The following is a description of a gene set: studied in species Mus musculus Mouse Gene Set: CUI_CDC1_IFNA1_RESPONSE_UP Cytokines mediate cell-cell communication in the immune system and represent important therapeutic targets. A myriad of studies have highlighted their central role in immune function, yet we lack a global view of the cellular responses of each immune cell type to each cytokine. To address this gap, the authors created the Immune Dictionary, a compendium of single-cell transcriptomic profiles of more than 17 immune cell types in response to each of 86 cytokines (>1,400 cytokine-cell type combinations) in mouse lymph nodes in vivo. A cytokine-centric view of the dictionary revealed that most cytokines induce highly cell-type-specific responses. For example, the inflammatory cytokine interleukin-1β induces distinct gene programmes in almost every cell type. A cell-type-centric view of the dictionary identified more than 66 cytokine-driven cellular polarization states across immune cell types, including previously uncharacterized states such as an interleukin-18-induced polyfunctional natural killer cell state. from publication Cui A, Huang T, Li S, Ma A, Pérez JL, Sander C, Keskin DB, Wu CJ, Fraenkel E, Hacohen N (PMID 38057668) Genes positively differentially expressed in cell type: cDC1 (conventional dendritic cell type 1) upon treatment with cytokine: IFN-α1 in mouse lymph nodes in vivo., and this is the list of marker genes: Traf1, Ccnd3, Fcer1g (Fc receptor, IgE, high affinity I, gamma polypeptide), Sec23b, Efhd2, Rcn2, Arpc5l, Nmi, Pbx1, Elac2, Fam241a, Srgn, Tapbpl, Etnk1, Dusp2, Rigi, Icam1, Sgcb, Ifi27l2a (NCBI Gene Id 76933), Xaf1, Tent2, Arf4, Usp15, Irf5, Cnp, Lap3, Mov10, Cd40, Rab7, Irgm1, Sdcbp, Prpf38b, Herc6, Pttg1ip, Tspo, Tpm3, Itga4, Ppa1, Ankrd17, Cdh15, Pgd, Zbp1, Arpc5, Max, Peli1, Selplg, Prkx, Ifi203, Zc3h12c (NCBI Gene Id 330940), Atp6v1g1, Fgl2, Ncoa7, Oasl2, Dtx3l, Apod, Dnaja1 (DnaJ heat shock protein family (Hsp40) member A1), Fbxw17 (NCBI Gene Id 97893), Gpr33, Ass1, Ap1g2, Il10ra, Naa20 (NCBI Gene Id 99228), Mycbp2, Tent5c, Trim34a, Parp12, P2ry14, Ttc39b, Capza2, Ifit3, Dnase1l3, Npc2, Gbp4, Aida, Zfp800, Mbd2, Scimp, Ifi205, Arhgap17, Flnb, Trim25, Vim, Psma4, Phf11a, Sema4f, Parp9, Ccdc86, Cyba, Map2k1, Cd86, Rbms1, G3bp2, Bag1, Tppp3, Acot9, Hk3, Nufip1, Cst3, Fcgr4 (Fc receptor, IgG, low affinity IV), Rnh1, Dnaja2, Dck, Gch1, Sar1a, Psme1, Ikzf1, Myd88, Gng5, Il27, Usp25, Ogfr, Serpinb9, Itgb1, Pmepa1, Eapp, Prdx1, Sri, Gadd45b, Neat1, Calm1, Cfap126, Rngtt, Otud5, Rab5c, H2-T22, Cdkn1a, Sco1, Cybb (cytochrome b-245, beta polypeptide), Tbl1x (transducin (beta)-like 1 X-linked), Ifi47, Lnpep, Cdc42bpg, Selenow, Phyh, Oasl1, Mitd1, Gpr157, Ifit3b, Nfkb2, Ywhae, Ddx24, Bbx, Sat1, Herpud1, Cd52, Serpina3g, Usp18, Hck, Acadl, Hsp90aa1, Keap1, Naa25, Akr1a1, Cd47, Lyn, S100a6, Lamp2, Pnp, Macir, Ifi206, Epsti1, Grb2, Nlrc5, Phf11b, Scarb2, Kpna3, H3f3b, Gng12, Hsd17b11, Cdc42 (NCBI Gene Id 12540), Mthfr, Pttg1, Psmb10, Ly75, Trim12a, Sh3glb1, Ywhah, Glrx, Ifi209, Plxnc1, Tbc1d1, Ifi35, Mpc1, Ildr1, Relb, Sfxn1, Rap2a (NCBI Gene Id 76108), Itm2b, Tapbp, Pgap2, Casp3, Bcl2a1b, Cd8a, Fchsd2, Hmgn3, Tmem184b, Pml, Tor1aip2, Iigp1, Srsf5, Reep3, Mtmr14, Arhgap8, Anxa7, Phf11c, Ehd1, Csrp1, Macroh2a1, Cln3, Map3k8, Sell, Mfsd12, Tpm4, Etv3, Ly6a, Stx11, Psme2, Grn, Ifi207, Slfn8, Themis2, Lgals3, Gatm, Samhd1, Ints8, Apool, Dusp5, Gbp9, Trim12c, Rtp4, Cxcl10, Nuak2, Vcpip1, Ifi208, Ifi204, Ttc7, Fbxo6, Tomm70a (translocase of outer mitochondrial membrane 70A), Vrk1, Cmtm6 (CKLF-like MARVEL transmembrane domain containing 6), Gng2, Tor1aip1, Trafd1, Tmpo, Nr4a3, H2-T23, M6pr, Cflar, Nsd3, Armcx3, Pmpcb, Psma3, Stat1, Snap23, Parp14, Hnrnph2, Il15, Oas1a, Stat2, Ppp1r2, Mcmbp (minichromosome maintenance complex binding protein), Sp100, Tle3, Trim30b, Slc25a22, Dnajc13, Isg20, Ehd4 (EH-domain containing 4), Mxd1, Timeless, Fbxw11, Morc3, Trim30d, Ndrg1, Aldh1b1, Stoml1, Igtp, Plaat3, Rnf114, Bri3, Tnfrsf1a (tumor necrosis factor receptor superfamily, member 1a), Ifih1, Tgtp1, Cpne2, St8sia1, Pik3cd, Slfn1, Gbp2, Pdha1, Slfn2, Rab11a, Cpne3, H2-K1, Phc2, Brd2, Hspa5, Rnf19b, Smg7, Map3k12, Rnf4, Ccnd1, Tomm34, Snx6, Map3k14, Spi1, Myl12a, Rnf213 (ring finger protein 213), Tcstv4, Slc8b1, Psma2, Anxa2, Nsmce1, Phf11d, Anxa1, Rrad, Triobp, Asb2, Xdh, Uqcrb, Lgals3bp, Card11, Atp1b3 (ATPase, Na+/K+ transporting, beta 3 polypeptide), Dek, Zc3hav1 (zinc finger CCCH type, antiviral 1), Nudt9, Stard3, Sap30, Cd38, Sppl2a, Ube2d3, Rufy3 (NCBI Gene Id 72186), Chmp4b, H2-D1, Bst2, Larp1b, Atp6v1e1, Rasa4, Ctsz, Mcl1, Tmem106a, Dbnl, Serpina3f, Laptm4b, Cd69, Anxa5, Lpxn, Csprs, Pfkp, Apobec3, Tdrd7, Procr, Rtraf (RNA transcription, translation and transport factor), Sdc3, Irf7, Ubr4, Inpp5b, Actr2, B4galt5, Oas3, Rnf34, Crlf3, Stxbp3, Gramd2b, Cct3 (chaperonin containing TCP1 subunit 3), Dhx58, Pcgf5, Adar, Ostf1, Uba7, Samd9l, Rsad2, Zyx, Nono, Trim30a, Ms4a6c, Gca, Tmem219, Daxx, Lpp, Ppp1r11, Plin2, Nfkbie, Pdia3 (NCBI Gene Id 18794), Treml2, Trib1, Ascc3, Bcl9, Tor3a, Krcc1, Bcl2a1d, Cmpk2, Sp140, Gypc, Nipsnap3b, Slfn5, Ms4a4b, Utp3, Sumo1, Cacybp, Eif2ak2, Kynu, Gnb2, Rab8a, Clec2d, Gnb4, Ciao2b, Helz2 (NCBI Gene Id 229003), Ly6c2, 9930111J21Rik2, Tmem131l, Mx1, Iqgap1, Cycs, Ifit1, Tap2, Litaf, Clic4, Gmppb, Sem1, Vdac2, Il18 (NCBI Gene Id 16173), Sct, Smarce1, Ifit2, Nrros, Wdfy1, Cd53, Zc3h7a, Acer3, Phf6, Rab10, Rab2a, Ifi44 (NCBI Gene Id 99899), Aftph, Cdc42se1, Sbno2, Wfdc17, Plac8, Atp6v1d, Ms4a4c, Svbp, Ube2l6, Cd274, Ms4a6d, Fyn, Cd83, Stat3, Evi2a, Arpc2, Slirp, Pdk3, Spop, Il2rg (interleukin 2 receptor, gamma chain), Mospd2, Rab22a, Nabp1, Coq2, Tmsb10, Ptpn6, Skap2, Arhgap30, Rab29, Parp11, Ptms, Gbp7, Znfx1, Ldha, Snx2, Txndc17, Mpp1, Prpf38a, Fdps, Isg15, Rpain, Xrn1, Nt5c3, Laptm4a, Fndc3a, Pim1, Rusc1, Tmem131, Bcl2a1a, Nampt, B2m, Gsdmd, Atf2, Psmb8, Ifi211, Rfc3, Psma5, Msn, Frmd4a, Mndal, Ccnd2, Ubc, Psmb9, Chmp5, Akt3, Nras, Txn1, Ddx60, Armcx6, Lmnb1, Cyria, Hdac1, Ube2l3, Cxcl9, Srsf3, Slc4a8, Sash3, Anxa4, Dpy19l1, Rab8b, Slc6a6, Ece1, Fndc5, Icos, Psma7, Gbp5, Casp8, Ilrun, Lgals9, Rap1b, Tcf7l2, Tmem51, Irf1, Rasgef1b, Sp110 (Sp110 nuclear body protein), Parp10, Pkib, Zup1, Mvp, Casp4, Calhm6, Hif1a, Klrk1, Eloc, Pdcd10, Gnb1, Marchf5, Tap1, Ifitm3, Ino80d, Shisa5, Coro2a, Ogfrl1, Dnajc7 (NCBI Gene Id 67633), Ifi213, Nrp1, Ms4a6b, Tmbim6, Adap2, Ly6e, Dcp2, Phlpp1